Given this list of marker genes VRK1, FOXM1 (forkhead box M1), ASPM, RRM2 (NCBI Gene Id 6241), TNFRSF6B, EIF4A1, CKS2, FGFBP1, NCAPG, ODC1, SERPINE2, ACTB, AURKA, ACTN1, TRIP13, EPHA2, CAPRIN2, TUBG1, ZWILCH, CDKN3, DUSP4, CEP55, here is a description of the gene set: Genes down-regulated late in HMEC cells (mammary epithelium) during acinar development in vitro. Nonmalignant human mammary epithelial cells (HMEC) seeded in laminin-rich extracellular matrix (lrECM) form polarized acini and, in doing so, transit from a disorganized proliferating state to an organized growth-arrested state. We hypothesized that the gene expression pattern of organized and growth-arrested HMECs would share similarities with breast tumors with good prognoses. Using Affymetrix HG-U133A microarrays, we analyzed the expression of 22,283 gene transcripts in 184 (finite life span) and HMT3522 S1 (immortal nonmalignant) HMECs on successive days after seeding in a lrECM assay. Both HMECs underwent growth arrest in G0-G1 and differentiated into polarized acini between days 5 and 7. We identified gene expression changes with the same temporal pattern in both lines and examined the expression of these genes in a previously published panel of microarray data for 295 breast cancer samples. We show that genes that are significantly lower in the organized, growth-arrested HMEC than in their proliferating counterparts can be used to classify breast cancer patients into poor and good prognosis groups with high accuracy. This study represents a novel unsupervised approach to identifying breast cancer markers that may be of use clinically. Human Gene Set: FOURNIER_ACINAR_DEVELOPMENT_LATE_DN from publication Fournier MV, Martin KJ, Kenny PA, Xhaja K, Bosch I, Yaswen P, Bissell MJ (PMID 16849555) studied in species Homo sapiens